The following is a description of a gene set: studied in species Mus musculus Mouse Gene Set: WP_METAPATHWAY_BIOTRANSFORMATION Metapathway biotransformation, and this is the list of marker genes: Gstcd, Cyp8b1, Cyp4b1, Gpx4, Gsta1, Cyp4v3, Cyp11b1, Nat8, Chst3, Comt, Ndst2, Cyp26b1, Nat14, Hs3st5, Cyp27b1, Ugt1a10, Cyp2u1, Gsr, Hs3st6, Hnmt, Gss, Ugt1a2, Sult1c2, Naa20, Cyp26c1, Nnmt, Sult1b1, Cyp4x1, Hs3st2, Hs2st1, Gstk1, Chst7, Hs3st3a1, Fmo2, Sult2a1, Ephx2, Chst2, Akr7a5, Ugt1a9, Mgst1, Cyp21a1, Gsta3, Hs3st3b1, Akr1a1, Akr1b1, Cyp19a1, Chst11, Cyp51, Naa50, Cyp26a1, Chst13, Naa40, Cyp7b1, Cyp46a1, Ugt1a1, Cyp2e1, Gsta2, Hs6st3, Naa80, Cyp17a1, Mgst3, Fmo1, Cyp1a2, Cyp11a1, Chst1, Chst12, Akr1b10, Gpx3, Sult1e1, Ndst3, Akr1d1, Chst9, Sult2b1, Hs6st2 (NCBI Gene Id 50786), Gal3st1, Nat10, Sult6b1, Nat2, Chst8, Hs6st1, Cyp24a1, Glyat, Hs3st1, Gal3st2, Gsto1, Cyp2w1, Inmt, Cyp27a1, Kcnab1, Gstz1, Hs3st4, Gstt1, Cyp39a1, Sult1a1, Gstm5, Sult4a1, Gal3st3, Chst10, Nat8l, Ugt1a5, Gpx2, Cyp7a1, Chst4, Ugt2a2, Cyp1b1, Gpx5, Gstm1 (glutathione S-transferase, mu 1), Gpx1, Gstm4, Mgst2, Tpmt (thiopurine methyltransferase), Ephx1, Gal3st4, Ndst1, Cyp2f2, Cyp2r1, Gstp1, Ndst4 (N-deacetylase/N-sulfotransferase (heparin glucosaminyl) 4), Naa30, Cyp11b2, Ugt1a6a, Kcnab2, Fmo5, Gsto2 (NCBI Gene Id 78155), Cyp2s1, Cyp20a1, Gstm7, Ugt2a3, Chst14, Fmo4, Fmo3, Nat9, Cyp1a1, Cyp4f39, Kcnab3, Baat, Gstt2, Cyp4f18, Gsta4, Chst5